Given this list of marker genes Gpat4, Pnpla3, Tmx1, Rbp2, Scarb1, Pck1, Nr1h2, Sik1, Agmo, Slc27a1, Lpl, Srebf1, Acsl6, Agpat2, Ctdnep1, Acsl4, Sirt1, Lpin1, C3, Gpat3, Plin5, Ldlr, Nr1h4, Apoc3, Lpgat1, Gpld1, Nr1h3, Mogat2, Lpin2, Thrsp, Rgn, Cnep1r1, Gk, Mfsd2a, Dgat2, Lpin3, Tmem68, Acsl5, Gpat2, Gpam, Tcf7l2, Pck2, Acsl1, Kat5, Dgat1, Mogat1, here is a description of the gene set: Mouse Gene Set: GOBP_TRIGLYCERIDE_BIOSYNTHETIC_PROCESS species: Mus musculus The chemical reactions and pathways resulting in the formation of a triglyceride, any triester of glycerol.